Given this list of marker genes ANP32E, UQCR10, CTH, RPS15A, MED21, ATP1A2, RPL17, SPP1, FUNDC2, RETREG1, WFDC2, PTTG1, MSX2, KRT7, SEM1, PPIA (NCBI Gene Id 5478), FEM1A, TK1, CTSZ, MYH4, EBP, RPL22L1, TOMM7, CRABP2, here is a description of the gene set: Human Gene Set: VIETOR_IFRD1_TARGETS from publication Vietor I, Vadivelu SK, Wick N, Hoffman R, Cotten M, Seiser C, Fialka I, Wunderlich W, Haase A, Korinkova G, Brosch G, Huber LA (PMID 12198164) Genes down-regulated in c-JunER cells (mammary gland epithelum) by overexpression of IFRD1 off an adenovirus vector. species: Mus musculus The mammalian SIN3 complex consists of histone deacetylases (HDAC1, HDAC2), several known proteins (SAP30, N-CoR) and as yet unidentified proteins. Here we show that the mouse tetradecanoyl phorbol acetate induced sequence 7 (TIS7) protein is a novel transcriptional co-repressor that can associate with the SIN3 complex. We have identified tis7 as a gene that is up-regulated upon loss of polarity in a mouse mammary gland epithelial cell line expressing an estrogen-inducible c-JunER fusion protein. In unpolarized cells, TIS7 protein levels increase and TIS7 translocates into the nucleus. Overexpression of tis7 causes loss of polarity and represses a set of genes, as revealed by cDNA microarray analysis. We have shown that TIS7 protein interacts with several proteins of the SIN3 complex (mSin3B, HDAC1, N-CoR and SAP30) by yeast two-hybrid screening and co-immunoprecipitations. TIS7 co-immunoprecipitated HDAC complex is enzymatically active and represses a GAL4-dependent reporter transcription. The transcriptional repression of endogenous genes by tis7 overexpression is HDAC dependent. Thus, we propose TIS7 as a transcriptional co-repressor affecting the expression of specific genes in a HDAC activity-dependent manner during cell fate decisions, e.g. scattering.